The following is a description of a gene set: SHC-mediated cascade:FGFR4 Human Gene Set: REACTOME_SHC_MEDIATED_CASCADE_FGFR4 species: Homo sapiens, and this is the list of marker genes: KLB, FGF4, SHC1, FGF19, FGF9, FGF2, FGFR4, KRAS, NRAS, FGF17, FGF6, SOS1, FGF16, HRAS, FGF18, FGF8, GRB2, FGF23, FGF20, FGF1